The following is a description of a gene set: from publication Cui A, Huang T, Li S, Ma A, Pérez JL, Sander C, Keskin DB, Wu CJ, Fraenkel E, Hacohen N (PMID 38057668) Mouse Gene Set: CUI_T_CELL_CD4_CD30L_RESPONSE_DN Cytokines mediate cell-cell communication in the immune system and represent important therapeutic targets. A myriad of studies have highlighted their central role in immune function, yet we lack a global view of the cellular responses of each immune cell type to each cytokine. To address this gap, the authors created the Immune Dictionary, a compendium of single-cell transcriptomic profiles of more than 17 immune cell types in response to each of 86 cytokines (>1,400 cytokine-cell type combinations) in mouse lymph nodes in vivo. A cytokine-centric view of the dictionary revealed that most cytokines induce highly cell-type-specific responses. For example, the inflammatory cytokine interleukin-1β induces distinct gene programmes in almost every cell type. A cell-type-centric view of the dictionary identified more than 66 cytokine-driven cellular polarization states across immune cell types, including previously uncharacterized states such as an interleukin-18-induced polyfunctional natural killer cell state. Genes negatively differentially expressed in cell type: CD4+ T cell upon treatment with cytokine: CD30L in mouse lymph nodes in vivo. species: Mus musculus, and this is the list of marker genes: Fos, Klf6, Junb, Klf2, Jun, Ppp1r15a